Given this list of marker genes FASTKD5, HSD17B10, LONP1, TFB2M, HADHA, HADHB, FASTKD2, VDAC1, DNAJA3, ATAD3A, MTNAP1, TUFM, SSBP1, HSPA9, TRMT10C, GRSF1, ACADVL, DDX28 (DEAD-box helicase 28), POLDIP2 (DNA polymerase delta interacting protein 2), TEFM, TFAM, SLC25A5, TOP1MT, SHMT2, SUPV3L1, DHX30, DNA2, TERT, DBT, ELAC2, POLG, SOD2, POLRMT, VDAC2, MTERF1 (NCBI Gene Id 7978), CLPX, LRRC59, UQCC2, CPS1, MPG, TWNK, PRORP, POLQ, POLG2 (NCBI Gene Id 11232), LRPPRC, ATP5F1B, TFB1M, MTERF2, PIF1, here is a description of the gene set: species: Homo sapiens The region of a virus, bacterial cell, mitochondrion or chloroplast to which the nucleic acid is confined. Human Gene Set: GOCC_NUCLEOID